The following is a description of a gene set: species: Mus musculus Mouse Gene Set: chr11B3, and this is the list of marker genes: Arhgef15, Slc16a11, Cntrob, Myh10, Gltpd2 (NCBI Gene Id 216871), Chrne, Per1, Myh1, Gm12312, Nlgn2, Borcs6, B130011K05Rik, Sco1, Map2k4, Rangrf, Gp1ba, Gm12288, Kdm6bos, Mir324, Arhgap44, C78197 (NCBI Gene Id 97702, expressed sequence C78197), Odf4, Kdm6b, Tnfsf13os, Dvl2, Sox15, Eno3, Spem3, Gm12295, Gm12297, Zmynd15, Gm23506, Ccdc42, Ccdc42os, Inca1, Polr2a, Myh2, Zfp3, Gm12320, Cox10, Stx8, Psmb6, Slc35g3, Gm40193, Usp43, Gm23194, 9130017K11Rik, Cyb5d1, Fgf11, Alox15, Cdrt4os1, Hs3st3b1, Cldn7, Mir1934, Rnf227, 2310065F04Rik, Wrap53, Gm12315, Mir497 (NCBI Gene Id 751537), Shisa6, Alox8, Elac2, 2810408A11Rik, Tnfsf12, Cdrt4os2, Ybx2, Cdrt4, Tnfsf13, Gm12304, Cd68, Phf23, 9630013K17Rik, Efnb3, Mir744, Mir3062, Gm12285, Gm12289, Tm4sf5, Slc25a11, Gm12301 (predicted gene 12301), Gm12298, Trappc1, Hes7, Gm12310, Arrb2, Gm12311, Chd3, Spem2, 1700086D15Rik, Rcvrn, Mpdu1, Neurl4, Pelp1, Spag7, Pik3r5, Tekt3, 2810001G20Rik, Myh4, Gps2, Gm22442, Mir7115, Atp1b2, Rnf222, Zkscan6, Gabarap, Ctc1, Dlg4, Gas7, Gm12314, Mir497b, Plscr3, Mir6923, Scimp, Pfn1, Rnasek, Gm12307, Gm12313, Myocd, Alox12e, Mir195a, Ndel1, Tmem102, 0610010K14Rik, Snord118, Gm12286, Myhas, Gsg1l2, Gm53042 (NCBI Gene Id 115487730), Gm12308, Tnfsfm13, Fxr2, Med11, Pfas, Mir6406, Spem1, Ntn1, Gm12292, Pirt, Trp53, Kif1c, Alox12b, Myh13, Mir6925, Elp5, Zbtb4, Clec10a, Eif4a1, Eif5a, Acap1, Cntrobos, Glp2r, Alox12, Dhrs7c, Mgl2, Kcnab3, Rpl26, Aurkb, Ctdnep1, 9330160F10Rik, 4930544D05Rik, Tmem95, Shbg, Gm12290, Asgr1, 9430073C21Rik, Tmem220 (transmembrane protein 220), Mir6924, Mfsd6l, Senp3, Pik3r6, Gucy2e, Bcl6b, 9130213A22Rik, B430319H21Rik, Tvp23bos, Adprm, Cfap52, Tnk1, Rnf167, Cxcl16, Dnah2, Tmem107, Gm24029, Gm12287, Sat2, Dnah9 (NCBI Gene Id 544786), Slc2a4, Gm12318, Gm12293, Pld2, Mink1, Gm26128, Gm12296, Tmem238l, Pmp22, Slc25a35, Gm25835, Tmem88, Slc16a13, Tmem256, Dnah2os, Mir467f, Camta2, Asgr2, Vmo1, Myh8, Aloxe3, Vamp2, Naa38, Myh3, Acadvl, Hs3st3a1, Chrnb1, Gm12299, Kctd11, Hmgb1-ps3